The following is a description of a gene set: studied in species Homo sapiens Human Gene Set: GOBP_RETINOL_METABOLIC_PROCESS The chemical reactions and pathways involving retinol, one of the three compounds that makes up vitamin A., and this is the list of marker genes: ADH6, ADH1B, PNPLA4, AKR1B15, CEL, RDH16, CYP3A5, CYP2C8, PNPLA2, ADH4, LRAT (lecithin retinol acyltransferase), RDH8, CYP27C1 (cytochrome P450 family 27 subfamily C member 1), ALDH1A3, ADH1A, ALDH1A1, ADH7, SDR9C7, ADH1C, RDH14, RDH5, SDR16C5, DGAT2, DHRS4, CYP2C18, RDH12, LIPE, DGAT1 (diacylglycerol O-acyltransferase 1), RPE65, CYP1A1, PNLIP, AKR1B1, AWAT2, CYP3A7, RDH10, AKR1C3, RDH13 (NCBI Gene Id 112724), RBP4, PLB1, CYP2D6, HSD17B6, AKR1B10 (NCBI Gene Id 9405), CYP1A2, ALDH1A2, CYP1B1, RETSAT, DHRS7, RDH11, BCO1, CYP3A4, DHRS9, DHRS3 (dehydrogenase/reductase 3)